Given this list of marker genes CCND2, LIF, NOLC1, LTA, MAT2A, IL2RA, SOCS2, DKC1, NOP56, NOP16, here is a description of the gene set: Human Gene Set: FUNG_IL2_SIGNALING_1 from publication Fung MM, Chu YL, Fink JL, Wallace A, McGuire KL (PMID 15735688) Genes up-regulated by IL2 in both primary thymocytes and T1 cells (primary thymocytes immortalized by Tax, an HTLV-1 encoded gene). Interleukin-2 (IL-2) mediates cell cycle progression and antiapoptosis in human T cells via several signal transduction pathways. The Tax protein of the human T-cell leukemia virus type I (HTLV-1) deregulates cell growth and alters the role of IL-2 in infected cells. However, Tax-immortalized cells stay dependent on IL-2, suggesting that events besides HTLV-1 gene expression are required for leukemia to develop. Here, IL-2-dependent and -independent events were analysed in a human T cell line immortalized by Tax. These studies show that, of the signaling pathways evaluated, only STAT5 remains dependent. Microarray analyses revealed several genes, including il-5, il-9 and il-13, are uniquely upregulated by IL-2 in the presence of Tax. Bioinformatics and supporting molecular biology show that some of these genes are STAT5 targets, explaining their IL-2 upregulation. These results suggest that IL-2 and viral proteins work together to induce gene expression, promoting the hypothesis that deregulation via the constitutive activation of STAT5 may lead to the IL-2-independent phenotype of HTLV-1-transformed cells. species: Homo sapiens